Given this list of marker genes SSC4D, SGTA, ZNF747-DT, IMPACT, MAPK8IP2, NUMA1, KHSRP, ZNF524, SURF6, TRNAU1AP, ANKRD13A, VILL, ZSCAN31, LINC00235 (NCBI Gene Id 64493), UQCRH, TPH2, BANCR, GNL3L, ZNF805, AMBRA1, TMED1, RIN3, CDH23, UBE3C, TMEM9, WIPF1, NDC1, CTCFL, OAZ1, LDAH, USP32, GARIN5A, LILRP1, TKT, ZFP37, SNX5, ZNF175, TRNT1, MPND, REEP3, GPR158, EZR, ZFYVE27, STX5-DT, ENSG00000189229, WDSUB1 (NCBI Gene Id 151525), CDCA3, CUL5, TM9SF4, MTMR9, APAF1, CA12, PCID2, MAGOH-DT, CFAP96, TMEM11 (NCBI Gene Id 8834), TIMM50, CSNK1E, FKBP5, SCAND3, ZNF649, MEF2C-AS1, ANKZF1, MKS1 (NCBI Gene Id 54903), MGME1, ABCA5, SAMD9L, PDE12, NAGLU, ENOPH1 (enolase-phosphatase 1), EOGT, SNORD3J, LINC00885, RAD9B, SMIM20, ACTR3C, PCBP1-AS1 (PCBP1 antisense RNA 1), NADK, SIGLEC6, ANKS6, GLTC1, VMP1, RBBP4 (RB binding protein 4, chromatin remodeling factor), AP1G1, GNG4, NUDT18, ASPSCR1, CLIC4P2, SCYL3, RPL10P7, PPID, HADHBP1, NSUN4, DHX58, NFE2L2, TTC33, ZNF280C, ORMDL3, RPS20, ACBD5, RNU6-194P, SHROOM1, CHD2 (NCBI Gene Id 283680), RRP1B (NCBI Gene Id 23076), RPF1, ZNF821, LNCATV, HOXB2, SPG11, ZNF596, GABPB2, CMTM3, ZNF8, NBPF11, NAPEPLD, ENSG00000237346, MTX3, ENSG00000263280, TMEM11-DT, IQCK, CAST, SPATS2, CTDP1, IFI27, SPHK1 (sphingosine kinase 1), DOLPP1, ENDOV, C3orf38, POLR2J3, MLXIP, HNRNPDL, FUZ, CLPX, SLC25A6 (NCBI Gene Id 8283), C2orf49, MAK16, RNU6-1227P, DNA2, SSBP4, LINC02985, FNBP1P1 (NCBI Gene Id 100533642), DHX40, ZNF484, TCERG1, H3-3B, LINC01215, FAM81B, VARS2, ISG15, PCBP4, ZCCHC7, STXBP5-AS1, MYO15A, IFTAP, AKT2, GLRA1, LDHA, GSDMC, MAG, WBP1L, UBALD2, LINC02252, ZNF561-AS1, LINC01347, RBM14, RNU6-761P, SNX12, FIZ1, EMC10, KIF2C, ZFYVE1, AGPS, ERI1, CTSF, MAZ, PPP4R1L, XIST, B3GNT5, PPP1R3D, CCDC136, SNORD48 (small nucleolar RNA, C/D box 48), PHF8, DPAGT1, PTOV1, DYNLT4, RFC4, MIER1, CEP95, EBLN3P, MIR7-3HG, MDH1, PLAA, KCTD21-AS1, ABCA17P, RNA5SP478, NFIA-AS1, SCGN, LL0XNC01-250H12.3, PRXL2B, TMEM181, NDUFS8, C2CD2L, THBS4, ADCK2, ZNF8-ERVK3-1, POGZ, LINC03016, C1orf159, NOSIP, TASOR2, ANKRD65, HTR5A, MEF2C, OR8F1P, OPLAH, C11orf21, ZNF280D, RFX1, MRPL3, GTF2H4, MED24, LINC01257 (NCBI Gene Id 116437), FBXW11, PSME2P3, TTC23, TOR3A, ARFGAP3, ABCA3, PKN1, GTF2A1, GTF2IRD1, SUSD1, THUMPD3, SH3BP5L, TULP3, TPGS1, ATF7IP2, F2RL3, STX5, NPRL3, NTPCR, MUC20-OT1, CAPN15, CYB5R4, CPEB4, CCZ1P1, MFSD14CP, IFI16, RALGDS, AHI1, LINC01732, TASOR, SHLD1, FYN, MRPS21, ZBTB8OS, MBNL1-AS1, OSTM1, C1orf74, MYLK-AS1, TMEM14B, PEMT (NCBI Gene Id 10400), BOD1, KAT5, EIF1AD, NIFKP7, RBAK, RBAK-RBAKDN, PCCB, STAP2, FTH1, EIF3B (NCBI Gene Id 8662), PPIH (NCBI Gene Id 10465), SEC14L1, BTF3, KAT6A, RHNO1, HOXB-AS1, PCSK6, ALDH5A1, ARMCX6, MTF2 (NCBI Gene Id 22823), CCAR2, VPS29, PPFIA4, LAMTOR1, MAN1C1, DIAPH1, NELFE, TARBP1, EFCAB14, NR3C1, SLC8B1, CHD4, VASP, PCMT1, SNAP25-AS1, EGLN2, PKD1L2, RNU6-951P, SLC34A1, TBX6, NELFA, FKBP2, LEMD2, CUL4A, CHFR (NCBI Gene Id 56732), RGS20 (regulator of G protein signaling 20), ABHD14A-ACY1, PMS2CL, SYNGR3, NOD2, NEUROD4, CPNE2, IKBIP, BCAS2, RPL29P20, LSM10, REXO4, ENSG00000231119 (NCBI Gene Id 101927377), C1orf174, CHMP3, DDR1, MAML3, C19orf38, SEL1L3, CCDC124, RFC1, TMEM241, SKIC2, PPT1, SFT2D2, SH2D6, CARD8 (caspase recruitment domain family member 8), LINC02934, DDX23, PIGL, LRRC28, CERNA3, FBXL19, HM13, PYCR1, IFT74, UBE2B, SEC24C, MAGOH, SYF2, HSF2BP, ZMYND8, B3GAT3P1, RNU1-108P, METTL3, ENSG00000253986, SNHG32, SNHG20, PRKACA, FNBP4, RFX3-DT, FCSK, SNX9, UTP11, SAXO5, ZNF688, PDE4A, COL4A2, PGM5P4, CAMKMT, NADK2, P4HB, GLB1L2, JMJD6, COPS6, UBE2D2, MED25, CALCOCO1, NAIF1, FEM1A, SNORD54, LINC00824, RHPN2, CARD8-AS1, UBR3, PPP5D1P, RBL1, TRMT12 (tRNA methyltransferase 12 homolog), MLST8, BARHL1, LRRC41, TBCD, PGP, PRPSAP1, BAZ2B-AS1, ACACA, IPP, MIR3124, ZNF79, NINJ2, ASAP3, CGGBP1, RPS14, WDR73, TARBP2, CCAR1 (NCBI Gene Id 55749), CCNI, ARID4A, ST3GAL2, CXXC1, CTDP1-DT, KCNAB1, EGOT, BMAL1, ZNF644, HNRNPC, RENBP, LRRC61, PCK1, ENSG00000213963, GDAP1, ASPH, PRICKLE3, RNU5F-1, WSB1, RNVU1-15, ADGRV1, UBE2O, TPTEP1, LINC02608, RNF213-AS1 (NCBI Gene Id 100294362), ENSG00000206898, TMEM165, AP3B2, PSMA3-AS1, SLC39A3, MACROH2A1, RPL23AP53, CNDP2, TRIP6, SPTLC1, CHFR-DT, CALM3, UBA5, IKBKB-DT, CDC16, C2orf49-DT, BANF1, SH3GLB1, RNA5SP60, PTBP1, HID1, CHRNB1, CHEK1, MIR4766, PLEKHF2, MR1, LHFPL4, SKAP2, TULP2, BAIAP2, DIAPH1-AS1, SLMAP, ATG9A, WDPCP, PREPL, ENSG00000227706, SFXN3, CCDC137, PIGZ, GAREM2 (NCBI Gene Id 150946), NSMCE1-DT, RMI2, BTBD19, RFX3, PEDS1-UBE2V1, USF1, ANKRD13D, CLPB, EHD4, RPS27, PABPN1, VDAC2, CLN5, UFSP2, CIMIP6, IL5RA, LEPROTL1 (leptin receptor overlapping transcript like 1), BCAT1, PEDS1, PANK4, HNRNPA0, LYN, TPRKB, BRWD1, ENTPD1-AS1, DNAJA2-DT, OSBP, DNAJA2, OSBPL8, ALG1L13P, CCDC112, USP9X, MYL4, DHRSX, NUDCD3, CCDC88A, CALCRL-AS1, STRIP1, ARMH4, HES4, MIR7-3, ABHD14B, SLC30A5, VTI1B, SVOP, HACD2, NBPF12, ZNF561, SUCLG1, CRYBG2, CCZ1B, TSSK3, here is a description of the gene set: from publication Yevshin I, Sharipov R, Kolmykov S, Kondrakhin Y, Kolpakov F (PMID 30445619) Genes containing one or more binding sites for (CREB3) in their promoter regions (TSS -1000,+100 bp) as identified by GTRD version 20.06 ChIP-seq harmonization. species: Homo sapiens Human Gene Set: CREB3_TARGET_GENES